Given this list of marker genes DLG1, DLG3, CALM1, DLG4, GRIK2, GRIK3, NCALD, GRIK4, GRIK1, GRIK5, here is a description of the gene set: Human Gene Set: REACTOME_IONOTROPIC_ACTIVITY_OF_KAINATE_RECEPTORS studied in species Homo sapiens Ionotropic activity of kainate receptors